Given this list of marker genes SGSH, here is a description of the gene set: part of: Mucopolysaccharidoses studied in species Homo sapiens Reactome Pathway: MPS IIIA - Sanfilippo syndrome A Mucopolysaccharidosis III (MPS III, Sanfilippo syndrome) was described in 1963 by a pediatrician named Sylvester Sanfilippo (J. Pediat. 63: 837-838, 1963, no reference). Mucopolysaccharidosis IIIA (MPS IIIA, Sanfilippo syndrome A, MIM:252900) is a rare, autosomal recessive lysosomal storage disease characterised by severe CNS degeneration in early childhood leading to death between 10 and 20 years of age. A deficiency of the enzyme N-sulphoglucosamine sulphohydrolase (SGSH, MIM:605270), which normally hydrolyses the sulfate group from the terminal N-sulphoglucosamine residue of heparan sulfate (HS), leads to the build-up of HS in cells and tissues and its presence in urine (van de Kamp et al. 1981, Yogalingam & Hopwood 2001, de Ruijter et al. 2011). The gene encoding N-sulfoglucosamine sulfohydrolase, SGSH, was cloned in 1995 (Scott et al.1995) and, later, shown to contain 8 exons spanning approximately 11 kb.